The following is a description of a gene set: Any process that stops, prevents, or reduces the frequency, rate or extent of a process involved in the formation, arrangement of constituent parts, or disassembly of cell projections. Human Gene Set: GOBP_NEGATIVE_REGULATION_OF_CELL_PROJECTION_ORGANIZATION studied in species Homo sapiens, and this is the list of marker genes: TACSTD2, THY1, CBFA2T2, BCL11A, TBC1D30, RNF6, DAB1, RUFY3, DTNBP1, KREMEN1, RTN4RL2, CEP97, LRP4, TNR, AMIGO3, EPHB2, EVL, KIF24, MIR196A1, MGARP, FAT3, EFNB3, SPP1, HRG, SEMA6C, MARCHF7, STX1B, EPHA7, MCF2, ZNF296, FYN, SEMA3G, LRRK2, VIM, GDI2, PTPN9, SRGAP2C, MAP4, CDK10, SNAPIN, B2M, RTCA, WNT3, SYNGAP1, MIR210, HDAC2 (histone deacetylase 2), MIR219A1, NEO1, PFN2, INPP5J, SPOCK1, ADAM17, SEMA4F, APOE, NGEF, ODF2L, ULK2, PRNP, PRKCD, ABI3, WNT3A, RAP1GAP, KANK1, ARPIN, MAG, PTPN1, PMP22, SEMA6D, CDH1, TCHP, CERS2, ITM2C, LRIG2, FGF13, LIMK2, DAB2, ZNF365, ACP4, SPRY3, SEMA3F, YAP1, GFAP, SPRY2, SEMA3A (NCBI Gene Id 63232), SEMA5A, DGUOK, PLXNB3, CD38, ARHGAP44, FIGNL2, LPAR1, TBX6, GFI1, CARM1, AKT1, INPP5F, CRMP1, WDR44, TRPC6, PRAG1, EFNB2, PSEN1, DCC, TSKU, MYLIP, TRIM32, RAB29, MDM2, MPHOSPH9, NLGN1, WNT5A, EFNA1, RIT2, STMN3, TRPC5 (NCBI Gene Id 7224), EVI5L (ecotropic viral integration site 5 like), SLIT2, ULK1, PAFAH1B1, LIMA1, ADCY6, THOC2, PTPRG, RYK, DIP2B, TESK1, NRXN1, CCL21, CDKL3, NEU4, ITGA3, ARF6, EPHA4, MAK, NR2F1, FKBP4, LUZP1, ARHGAP4, GAK, BAG5, RTN4RL1, GLCE, CFL1, GRIN2B, MIR30B, CIB1, RTN4R, PTPRS, CCP110, HES1 (NCBI Gene Id 3280), MAP2 (microtubule associated protein 2), RAB3IP, DKK1, TRIM46 (tripartite motif containing 46), SPART, TLX2, DPYSL5, NFATC4, NRP1, PPP3CA (NCBI Gene Id 5530), GDI1, ARHGAP24, RGMA, KIAA0319, YWHAH (NCBI Gene Id 7533), TBC1D7, NTN1, MT3 (NCBI Gene Id 4504), MINAR1, PTPRO, STAP1, PLXNA3, TRPV4, TRAK2, DENND5A (NCBI Gene Id 23258), STMN2, GORASP1, IL15RA, DPYSL3, CDK5, IFRD1, FSTL4, PAQR3, HDAC6, RAPGEF2, MIR214, DRAXIN, SLIT1, PTEN, RTN4 (NCBI Gene Id 57142)